Given this list of marker genes Aqp4, Gzmm, Fgl2, Gfra1, Cd151, Pla2g4f, Ptprg, Il7r, Srebf2, Rag2, H2-Q1, Glrx, Rab36, Ptgr1, Efnb1, Selenop, Zbed3, Nupr2, Rab6b, Ezh2, Ccnb1, Gfpt1, Slc3a2, Xrcc6, Slc16a1, Cdc20, Myh9, Prm1, Smarca4, Il6st, Gpam, Kmt2b, Rag1, Ap4b1, Cdkn3, Dnmt3a, Reln, Fcgr3, here is a description of the gene set: Mouse Gene Set: HOFFMANN_SMALL_PRE_BII_TO_IMMATURE_B_LYMPHOCYTE_DN Gene expression profiles of five consecutive stages of mouse B cell development were generated with high-density oligonucleotide arrays from as few as 2 x 10(4) ex vivo isolated and flow-cytometrically purified cells. Between 2.8% and 6.8% of all genes change on differentiation from one cellular stage to the next by at least twofold. The entire pathway involves differential expression of 10.7% of all genes. Previously known expression patterns of genes (like surrogate light chain, RAG-1/2, MHC class II, mel-14 antigen) are confirmed. The gene expression patterns of the proliferating pre-BI and large pre-BII cells on the one hand, and the resting immature and mature B cells on the other hand, are most similar to each other. Small pre-BII cells display a pattern that is transitional between these two groups. Most of the genes expressed in early precursors are involved in general processes, like protein folding or cell cycle regulation, whereas more mature precursors express genes involved in more specific molecular programs (cell surface receptors, secreted factors, and adhesion molecules, among others). Between 19 and genes share a given expression pattern. Combining knowledge about gene function and expression pattern allows identification of novel candidate genes potentially involved in self-maintenance of pre-BI cells, allelic exclusion and pre-B cell receptor signaling in large pre BII cells, cell-cycle arrest of small pre-BII cells, propensity toward apoptosis or anergization in immature B cells, propensity toward cell division and activation in mature B cells, and stage-specific interactions with stromal cells in the bone marrow. studied in species Mus musculus from publication Hoffmann R, Seidl T, Neeb M, Rolink A, Melchers F (PMID 11779835) Genes down-regulated during differentiation from small pre-BII to immature B lymphocyte.